Given this list of marker genes INPP5B, INPP5K, OCRL, MINPP1, INPP5J, PTEN, INPP5A, INPP5D, here is a description of the gene set: studied in species Homo sapiens Human Gene Set: GOMF_INOSITOL_TETRAKISPHOSPHATE_PHOSPHATASE_ACTIVITY Catalysis of the reaction: myo-inositol tetrakisphosphate + H2O = myo-inositol trisphosphate + phosphate.